Given this list of marker genes KCNE4, AMH, PLSCR3, DPP6, RBPMS2, TMEM123, ARVCF, EEF1A2, HES3, CPNE3, FHDC1, HTR3A, KIF5B, FUT8, CDK18, BUD13, CACNG4, FCGR1A, CBLN3, POU2F3 (POU class 2 homeobox 3), STMN2, RAB3IL1 (RAB3A interacting protein like 1), TSHZ2, BTC, SKAP2, HEBP1, MYOZ2, TMIGD1, UNK, RAP2B, FAM110C, CPOX, NRIP3, LAMA2, ISCA2 (NCBI Gene Id 122961), ZMAT2, ATP1A2, SLC30A4, RAB6A, TEAD3, RHBDF1, BAALC, OASL, TENM1, ECEL1, C4BPA, PRR12, PKD2L2 (polycystin 2 like 2, transient receptor potential cation channel), TLX3, PCDHB2, C11orf96, RRH, PIP5KL1, FOXI1, CD68, SLC22A17, TMCO5A, PABIR1, SYNPO, ESPN, SLC17A9, CXCR2, GRID2IP (Grid2 interacting protein), BOC, EDN2, CYP4F3, TFR2, HFE, ETV6, AMDHD1, DRD4, CLIP2, MTMR7, PTGES, ZBTB12, ASB17, PCTP, ACVR2A, IHH, FOXN4, TUT1, CFB, PCOLCE2, PRSS35, SLC12A1, BMP15, ACTN1, KSR1, KLF1, ART1, USP26 (ubiquitin specific peptidase 26), VANGL1, TYW5 (NCBI Gene Id 129450), BVES, LGR5, STRA6, CREB3L2, FAM174A, DEFB4A, ZC3H12C, TAT, FOXN1, HS1BP3, RAB3B, CTNND1, GRIP1, CREB3L4, ASGR2, PDZD9, ALKBH3, KRT20, BPIFB2 (NCBI Gene Id 80341), MTNR1A, TTC7B, C1S, FBN1, PIWIL2, KIAA0319L, GSPT2, CNOT7, GDI1, SEMA4G, PADI3, ELOVL2, DLC1, ACOX1, AKT3, SH3GL2, PCDHB11, STARD13, CHRNB2, CXADR, MYL3, KRT1, HOMER2, ZNF605, LHB, MYOCD, ACBD3, CPXM2, EVX2, OR13J1, TRDN, FABP9, CNTFR, CACNA1D, TNS2, HACD1 (NCBI Gene Id 9200), PLA2G12A, THBS4, MIGA2, NINJ2, STX3, CDHR1, CFLAR, PCYOX1, FZD2, CTTN, MUC1, ANGPTL1, TM2D1, ALLC, EQTN, ATRN, SLTM, FBXO16, PLA2G2A, PARVB, SEMA3A, UGT8, TMPRSS11D, PCBD2, POF1B, ZRSR2, RAI2, MATN2, CATSPER1, BLOC1S3, ORC3, SOX18, MT4 (NCBI Gene Id 84560), IL1RAP, ASB15, TNNI1, RS1, HSPB7, NRARP, OPRK1, ANXA4, CRELD1, REEP2, PCDHB5, TACR1, CAMKK1, DTX1, CACNG5, CHI3L1, SPSB4, C11orf91, FOLR2, here is a description of the gene set: CD8+ T cells play a crucial role in the clearance of intracellular pathogens through the generation of cytotoxic effector cells that eliminate infected cells and long-lived memory cells that provide enhanced protection against reinfection. We have previously shown that the inhibitor of E protein transcription factors, Id2, is necessary for accumulation of effector and memory CD8+ T cells during infection. Here we show that CD8+ T cells lacking Id2 did not generate a robust terminally-differentiated KLRG1hi effector population, but displayed a cell-surface phenotype and cytokine profile consistent with memory precursors, raising the question as to whether loss of Id2 impairs the differentiation and/or survival of effector-memory cells. We found that deletion of Bim rescued Id2-deficient CD8+ cell survival during infection. However, the dramatic reduction in KLRG1hi cells caused by loss of Id2 remained in the absence of Bim, such that Id2/Bim double-deficient cells form an exclusively KLRG1loCD127hi memory precursor population. Thus we describe a role for Id2 in both the survival and differentation of normal CD8+ effector and memory populations. from publication Knell J, Best JA, Lind NA, Yang E, D'Cruz LM, Goldrath AW (PMID 23325888) Genes up-regulated in KLRG1 low CD8 T effector cells during infection: wildtype versus ID2. species: Homo sapiens Human Gene Set: GSE41978_WT_VS_ID2_KO_KLRG1_LOW_EFFECTOR_CD8_TCELL_UP